Given this list of marker genes Prkg1, Trp53, Npy2r, Prkcg, Cry1, Bmal1, Opn5, Spsb4, Mapk10, Ppargc1a, Maged1, Uts2r, Rorc, Prox1, Fbxl3, Chrnb2, Per3, Timeless, Nkx2-1, Tardbp, Mapk8, Sik1, Nlgn1, Hnrnpd, Phlpp1, Ppp1ccb, Cort, Fxr1, Rorb, Drd3, Parp1, Rora, Pmch, Bhlhe40, Ptger4, Sfpq, Kdm5b, Adora1, Drd2, Rock2, Mtnr1b, Pasd1 (PAS domain containing repressor 1), Ezh2, Adrb1, Csnk1e, Mtor, Opn4, Fbxl21, Hdac3, Fbxw11, Csf2, Noct, Hcrtr2, Il6, Usp9x, Ppara, Pml, Hnf4a (NCBI Gene Id 15378), Atg7, Klf10, Npas2, Nps, Gsk3b (glycogen synthase kinase 3 beta), Piwil2, Cry2, Fbxw7, Ddb1, Ube3a, Mapk9, Prkaa1, Ptgds, Drd4, Srrd, Sin3a, Ghrhr, Cipc, Prkdc, Per1, Drd1, Pspc1, Usp2, Top2a, Casp1, Kcna2, Uts2, Magel2, Kdm2a, Usp7, Atoh7, Clock (NCBI Gene Id 620729), Ccar2, Ghrl (NCBI Gene Id 80454), Pde6b, Sox14, Per2, Nr1d2, Adora2a (NCBI Gene Id 11540), Zfhx3, Kat5, Bmal2, Kdm5c, Prkaa2 (NCBI Gene Id 66516), Csnk1d, Ppp1cb, Btrc, Id2, Ppp1ca, Pparg, Mta1 (NCBI Gene Id 116870), Rbm4, Cdk1, Ppp1cc, Siah2, Thrap3, Crtc1, Oprl1, Sirt6, Ada, Adcy1, Ptger3, Nmu, Lepr, Nr2f6, Alb, Nr1d1, Rbm4b, Nono, Ghrh, here is a description of the gene set: species: Mus musculus Any process that modulates the frequency, rate or extent of a circadian rhythm. A circadian rhythm is a biological process in an organism that recurs with a regularity of approximately 24 hours. Mouse Gene Set: GOBP_REGULATION_OF_CIRCADIAN_RHYTHM